The following is a description of a gene set: studied in species Mus musculus Mouse Gene Set: WP_SEROTONIN_AND_ANXIETYRELATED_EVENTS Serotonin and anxiety-related events, and this is the list of marker genes: Plcd4, Crh, Plek, Htr1a, Arc, Crhr1 (NCBI Gene Id 12921), Nlgn1, Ppp3ca, Htr2c, Prkcb, Fos, Grin2d